Given this list of marker genes UBE2L3, FGFR3, ZC3H12D, CD63, FOXK2, MCL1, HSPA5, ZNF91, DAD1, UBB, MSI1 (musashi RNA binding protein 1), S100A4, ISG20, ANXA2, CD68, WT1-AS, JUND, TRIM32, PSME2, HAX1, FOS, XRCC5, GSTM4, EPOR, NACA, PIM2, DDX18, KRT8, NFKBIA, COL11A2, CALR, XBP1, RELB, JUN, DBI, TERT, FZR1, FLT3LG, SSR4, IFITM1, PSMA2, LDHB, HSP90B1, AXL, CSF2, TGFB3, KPNA4, LIFR, UQCR11, VAV2, USP22, LY96, RHOD, USP9X, CSF1, CXCR4, HSPE1, CYB561D2, CNNM2, KATNB1, EEF1A1, UBC, HCLS1, PSMB1, TMC6, RAN, ACVRL1, ABCC3, TNFRSF17, PAK3 (p21 (RAC1) activated kinase 3), CALM2, CANX (calnexin), ANGPT1, USF2, EIF4G2, CFLAR, FKBP2, here is a description of the gene set: from publication Munshi NC, Hideshima T, Carrasco D, Shammas M, Auclair D, Davies F, Mitsiades N, Mitsiades C, Kim RS, Li C, Rajkumar SV, Fonseca R, Bergsagel L, Chauhan D, Anderson KC (PMID 12969976) Human Gene Set: MUNSHI_MULTIPLE_MYELOMA_UP Genetic heterogeneity between individuals confounds the comparison of gene profiling of multiple myeloma (MM) cells versus normal plasma cells (PCs). To overcome this barrier, we compared the gene expression profile of CD138+ MM cells from a patient bone marrow (BM) sample with CD138+ PCs from a genetically identical twin BM sample using microarray profiling. Two hundred and ninety-six genes were up-regulated and genes were down-regulated at least 2-fold in MM cells versus normal twin PCs. Highly expressed genes in MM cells included cell survival pathway genes such as mcl-1, dad-1, caspase 8, and FADD-like apoptosis regulator (FLIP); oncogenes/transcriptional factors such as Jun-D, Xbp-1, calmodulin, Calnexin, and FGFR-3; stress response and ubiquitin/proteasome pathway-related genes and various ribosomal genes reflecting increased metabolic and translational activity. Genes that were down-regulated in MM cells versus healthy twin PCs included RAD51, killer cell immunoglobulin-like receptor protein, and apoptotic protease activating factor. Microarray results were further confirmed by Western blot analyses, immunohistochemistry, fluorescent in situ hybridization (FISH), and functional assays of telomerase activity and bone marrow angiogenesis. This molecular profiling provides potential insights into mechanisms of malignant transformation in MM. For example, FGFR3, xbp-1, and both mcl-1 and dad-1 may mediate transformation, differentiation, and survival, respectively, and may have clinical implications. By identifying genes uniquely altered in MM cells compared with normal PCs in an identical genotypic background, the current study provides the framework to identify novel therapeutic targets. species: Homo sapiens Genes up-regulated in multiple myeloma (MM) compared to normal plasma cells from the patient's identical twin.